Given this list of marker genes Grcc10, Fmc1, Mdga2, Elp6, Tuba1a, Ormdl1, Mfsd2a, Dpp4, B4galnt1, Borcs7, Sgsh, Lonrf2, Vps54, Gmppa, Spg11, Bcl7a, Pmp22, Cntnap2, Naglu, Ormdl3, Slc1a1 (solute carrier family 1 (neuronal/epithelial high affinity glutamate transporter, system Xag), member 1), Dctn1, Atp1b2, Vps13a, Gabrb3, Adarb1, Nr3c1, Prkaa1, Ndufs4, Atp1a3, Gm2990, Grpr, Iglon5, Wdr47, Gba1, Grp, Kcnq3, Kcnq2, Pfkfb3, Mfsd8, Ext1, here is a description of the gene set: Mouse Gene Set: GOBP_MOTOR_BEHAVIOR The specific neuromuscular movement of a single organism in response to external or internal stimuli. studied in species Mus musculus